The following is a description of a gene set: The gene expression program underlying the specification of human cell types is of fundamental interest. The study authors generated human cell atlases of gene expression and chromatin accessibility in fetal tissues. For gene expression, the study authors applied three-level combinatorial indexing to >110 samples representing 15 organs, ultimately profiling ~4 million single cells. The study authors leveraged the literature and other atlases to identify and annotate hundreds of cell types and subtypes, both within and across tissues. Our analyses focused on organ-specific specializations of broadly distributed cell types (such as blood, endothelial, and epithelial), sites of fetal erythropoiesis (which notably included the adrenal gland), and integration with mouse developmental atlases (such as conserved specification of blood cells). These data represent a rich resource for the exploration of in vivo human gene expression in diverse tissues and cell types. species: Homo sapiens from publication Cao J, O'Day DR, Pliner HA, Kingsley PD, Deng M, Daza RM, Zager MA, Aldinger KA, Blecher-Gonen R, Zhang F, Spielmann M, Palis J, Doherty D, Steemers FJ, Glass IA, Trapnell C, Shendure J (PMID 33184181) Marker genes curated from the annotated cluster as represented in the Descartes Human Gene Expression During Development database. Human Gene Set: DESCARTES_FETAL_STOMACH_MYELOID_CELLS, and this is the list of marker genes: PTAFR, IDO2, SPI1, CCDC26, C1QB, TBXAS1, HLA-DRB1, HLA-DMA, CD84, IRF8, HLA-DPA1, CPVL, ITGAX, FCER1G, HLA-DQA1, GCA, HACD4, MS4A7, CD300A, LINC00996, RUBCNL, NCF2, S100A8, MYO1F, CSF2RA, CD163L1, CLEC7A, CYBB, C1QC, CD4, MS4A6A (NCBI Gene Id 64231), PLEK, ADGRE2, FLT3, HLA-DRA, RILPL2, HLA-DRB6, TYROBP, CST3, C1QA, HLA-DRB5, DNASE1L3, NFAM1 (NFAT activating protein with ITAM motif 1), IDO1, ATP8B4, HLA-DQB1, ADAP2, MS4A4E, TNFRSF1B, IGSF6, CD83, HLA-DPB1, NAPSB, IL1B, TRPM2, MERTK, LTV1 (NCBI Gene Id 84946), FGD2, HCK, CSF3R, ALOX5, MPEG1, NR4A3, CD14, CD86, IFI30, CD74, MMP9, CIITA, PLAUR, PIK3AP1, LY86, HLA-DMB (NCBI Gene Id 3109), JAML, WDFY4, PLD4